Given this list of marker genes Sfmbt2, Strn, Ctcfl, Pcdhb4 (protocadherin beta 4), Mapre1, Spib (NCBI Gene Id 272382), Atg4d, Slc5a3, Nkx2-2, Csnk1a1, Ppp4r3a, Srsf3, Celf1, Ark2n, Mr1, Tpbg, Rc3h2, Dsp, Dmrta1, Mycs, H2-Ob, Pcmtd1, Tmem50b (NCBI Gene Id 77975), Rpl32l, Pank3, Zfp446, Coa3, Plagl1, Zfp868, Pramel27, Uspl1, Arfgap2, Clock, Afdn, Adipoq, Csgalnact2, Rer1, Rcan2, Becn1, Rexo1, Stxbp3, Setd1b, Mapk8 (mitogen-activated protein kinase 8), Zbtb33, Mbnl1, Gxylt1, Mylk4, Uty, Col4a2, Dock2, Nexmif, Ccl2, Atp6v0a4, Opn5, Akap13, Tet1, Anks1b, Nup35, Tm4sf1, Sgip1, Nudt11, Vcam1, Tmem170b, Zkscan8, Cadm2, Hp1bp3, Cdk12, Wdr44, Sh3bgrl2, Dab1, Shbg, 1700066M21Rik, Sptbn1, Zfp644, Rps6kb1, Eef2k, Sox2 (SRY (sex determining region Y)-box 2), Ccr2, Svbp, F11r, Ric3, Hdac8, Hbq1a, Rhpn2, Zfp1005, Btg3, Ccnyl1, Cep72, Zfp113, Crispld2, Gfral, Scn7a, D5Ertd579e, Edn3, Cnot6l, Nbr1, Cd40, Med7, Hbq1b, Extl3, Slc35e1, Zfp950, AI597479, Arrdc3, Arhgap15, Map3k1, Sec24a, Pcdh8, Cfl2, Cbln3, Trp63, Actbl2, Zfp729b, Zfp719, Pptc7, here is a description of the gene set: Genes predicted to be targets of miRBase v22 microRNA mmu_miR_292a_5p in miRDB v6.0 with MirTarget v4 prediction scores > 80 (high confidence targets). species: Mus musculus from publication Chen Y, Wang X (PMID 31504780) Mouse Gene Set: MIR_292A_5P